Given this list of marker genes Reln, Fyn, Vldlr, here is a description of the gene set: part of: Axon guidance This event has been computationally inferred from an event that has been demonstrated in another species.<p>The inference is based on the homology mapping from PANTHER. Briefly, reactions for which all involved PhysicalEntities (in input, output and catalyst) have a mapped orthologue/paralogue (for complexes at least 75% of components must have a mapping) are inferred to the other species. species: Mus musculus electronically inferred by orthology from the curated human pathway Reactome Pathway: Reelin signalling pathway